Given this list of marker genes EHHADH, ACADSB, DECR1, ECI1, ECHS1, ACAA2 (acetyl-CoA acyltransferase 2), ACSL3, HSD17B10 (NCBI Gene Id 50828), ACADL, here is a description of the gene set: Mitochondrial beta-oxidation Human Gene Set: WP_MITOCHONDRIAL_BETAOXIDATION studied in species Homo sapiens